The following is a description of a gene set: Mouse Gene Set: MIR_683 Genes predicted to be targets of miRBase v22 microRNA mmu_miR_683 in miRDB v6.0 with MirTarget v4 prediction scores > 80 (high confidence targets). from publication Chen Y, Wang X (PMID 31504780) species: Mus musculus, and this is the list of marker genes: Ermn, Grik3, Gapvd1, Arf4, Xcr1, Plppr4, Slc39a13 (NCBI Gene Id 68427), Pnn, Plscr4, Sec14l4 (SEC14-like lipid binding 4), Kpna4, Irs1, Plekhm2, Rnf185, Rassf2, Grin1, Dzank1, Larp4b, Cds2, Fam83f, Psmd5, Layn, Slmap, Tcp11l1, Cyb5r2, Nlgn3, Zfp704, Fam53c, A630023A22Rik, Hspa12a, Otor, Fmn2, Vwa8, Rfx7, Ostn, Aak1, Abl2, Caskin1, Kcnb1, Gopc, Rinl, Rasgrp3, Cadm3, Idi2, Dcun1d4, Sh2d1b1, Nav1, Ccnj, Kdm4a, Sh2b3, Thrb, Rtl5, Rbm34, Sp3, Nr6a1, Sema5a, Xylb, Slc6a16, Fcho2, Ralbp1, Ppp2r5e, Lrch3, Rapgef1, Steap2, Suv39h2, Tmem106a, Scrn1, Rapgefl1, Ube2g1 (ubiquitin-conjugating enzyme E2G 1), Rasal2, Zdhhc18, Fam124a, Morn4, Asb7, Kcna4, Peak1, Srpk1, Clec4d, Cdkal1, Kat6a, Phc3, Ubash3b, Sec62, Pld6, Cab39, Epha7, Itgae